Given this list of marker genes NT5M, NT5E, LACC1, NT5C1B-RDH14, PNP, HPRT1, NT5C1B, NT5C1A, NT5C2, NT5C, NT5DC4, here is a description of the gene set: studied in species Homo sapiens Human Gene Set: KEGG_MEDICUS_REFERENCE_PURINE_SALVAGE_PATHWAY_HYPOXANTHINE_GUANINE_TO_IMP_GMP Purine salvage pathway, hypoxanthine/guanine to IMP/GMP. Pathway ID: N01421. Pathway type: Reference. Pathway class: nt06027 Purine salvage pathway. Pathway Definition from KEGG: -- NT >> (PNP,LACC1) -> -- HPRT1 ->